The following is a description of a gene set: Human Gene Set: KEGG_MEDICUS_REFERENCE_GLUTATHIONE_BIOSYNTHESIS Glutathione biosynthesis. Pathway ID: N01589. Pathway type: Reference. Pathway class: nt06026 Glutathione biosynthesis. studied in species Homo sapiens Pathway Definition from KEGG: Cys+Glu -- (GCLC+GCLM) >> GSS -> GSH -- GPX -> GSSG, and this is the list of marker genes: GPX1, GPX4, GPX5, GCLM, GCLC, GSS, GPX7, GPX3, GPX8, GPX2, GPX6